Given this list of marker genes SOWAHA, LINC02915, CAMK1D, CASKIN2, DPYS, KLHL30-AS1, COG1, MCUB, CCDC15, FAM86C1P, FAM111B, ADAMTSL1, ALPK1, GABARAPL3, ENTPD3, CITED4, LINC01550, DUS4L, ARSL, ASCL3, FKRP, ALX4, TEX38, ANGPT4, BLCAP, C1orf210, AVPR1A, CCL4, C20orf202, DDX53 (DEAD-box helicase 53), FAP, DEPTOR, CXCL14, CHCHD7, EML3, ATXN3L, SUCO, CTSV (NCBI Gene Id 1515), CD46, COIL, CST3, ALKBH7, DGCR5, DHX58, FSIP1, AK9, PIEZO2, FGF13, CHRNA2, C11orf21 (chromosome 11 open reading frame 21), CARD10, FPGS, DDX18, BOLA1, DYNC1I1, ALOX12, FAM47A, LINC03040, FRAT2, C1QTNF7, FUS, CXXC1P1, ASB12, AP4B1, CDS1, CNOT4, COL10A1, ANKMY1 (NCBI Gene Id 54950), PXYLP1, LINC01949, TBATA, EIF2AK3, FNDC8, ARHGAP5 (NCBI Gene Id 394), CLTCL1, EEF1D (eukaryotic translation elongation factor 1 delta), PRDM16-DT, PAGR1, BDNF, CCNY, CYP4F29P, CYMP, GABRR3, FBXW9, MYRF-AS1, CFAP298, ARHGEF16, DNAJA4, DUSP14, CEP68, CCDC180, CAMSAP2, DNAH17, DOCK6, ARSJ, LINC00587, MVB12B, CLU, CDK5RAP2, BPIFB6, BTN1A1, DHRS9, CREB3L4, ASMTL-AS1, CAPZA3, DAAM2, C4orf36, LY6S-AS1, ABHD1, MVB12A, FTO, CYP7B1, GMNC, CA8, FITM1, FGF23, EMID1, CYP2J2, BTAF1, FBXO46, LINC02210, CEACAM1, CYSLTR2, BPI (NCBI Gene Id 671), FAM87A, ACTR3B, CHD9, EME1, CD7, EFNB1, ATXN1L, AFAP1, AMER1, FOS, ASB4, CCDC152, CST8, FAAP100, CYBB, TLCD3B, SCP2D1, ABCC8, ENTPD2, CSPG5, TBC1D32, BBOX1, ZNF736, CD3E, EPM2AIP1, BCDIN3D, CHRNG (NCBI Gene Id 1146), PRR29, CACNA1A, ENPP3, ERCC8, MFSD12, ARPIN, CNPY1, CD8B, CALCA, FAM181B, CUTA, C9orf40, ZNF436-AS1 (ZNF436 antisense RNA 1), BAALC-AS2, EOMES, ARIH1, CMTM5, CHL1, FKBP7, CPLX2, LINC01588, LINC00951, CCS, ANAPC15 (anaphase promoting complex subunit 15), ALK, ANKRD34A, CSTA, ACOT6, CACNG7, DACT1, CHPF, CABP2, DUS1L, ANKRD45, CHRNA4, GATC, FBH1, TRMT13, CNTFR, ECI2, CEACAM19, here is a description of the gene set: Gene expression profiles of subsets of CD4+ T cells according to their expression of FoxP3 and CD45RA were compared. FoxP3 is a key transcription factor for the development and function of natural CD4+ regulatory T cells (Tregs). Here we show that human FoxP3+CD4+ T cells are composed of three phenotypically and functionally distinct subpopulations: CD45RA+FoxP3low resting Tregs (rTregs) and CD45RA-FoxP3high activated Tregs (aTregs), both of which are suppressive in vitro, and cytokine-secreting CD45RA-FoxP3low non-suppressive T cells. The proportion of the three subpopulations characteristically altered in cord blood, aged individuals, and patients with immunological diseases. Terminally differentiated aTregs rapidly die while rTregs proliferate and convert into aTregs in vitro and in vivo as shown by the transfer of rTregs into NOD-scid-common gamma-chain-knockout mice and by TCR sequence-based T cell clonotype tracing in peripheral blood of normal individuals. Taken together, the dissection of FoxP3+ cells into subsets enables one to analyze Treg differentiation dynamics and interactions in normal and disease states, and to control immune responses through manipulating particular FoxP3+ subpopulations. Human Gene Set: GSE15659_RESTING_VS_ACTIVATED_TREG_UP species: Homo sapiens from publication Miyara M, Yoshioka Y, Kitoh A, Shima T, Wing K, Niwa A, Parizot C, Taflin C, Heike T, Valeyre D, Mathian A, Nakahata T, Yamaguchi T, Nomura T, Ono M, Amoura Z, Gorochov G, Sakaguchi S (PMID 19464196) Genes up-regulated in comparison of resting regulatory T cell (Treg) versus activated regulatory T cell (Treg).